The following is a description of a gene set: Mouse Gene Set: GOBP_OBSERVATIONAL_LEARNING Learning that occurs through observing the behavior of others. studied in species Mus musculus, and this is the list of marker genes: Nrxn2, Foxp2, Htt (NCBI Gene Id 319350), Pak1, Stra6, Nrxn1, Cntnap2, Shank3, Nf1, D130043K22Rik